Given this list of marker genes Arpc5, Lsm6, Pxdn, Plk3, Dnaja4, Pcyt1b, Vezf1, Fgfbp1, Commd6, Itm2b, Kank1, Tlcd4, Cnr1, Tmprss11e, Cdk17, Nt5c3b, Prkg1, Tsc1, Zcchc2, Sh3gl1, Gm13547, Otub2, Man1a2, Atrx, Cox6a1, Chchd6, Xaf1, Dicer1, Rapgef6, Lrrtm2, Rragc, Fbxl22, Tent5a, Nfib, Kdm2b, Sgcz, Cnot2, Cacnb2, Slc25a23 (NCBI Gene Id 66972), Calhm2, Hsd17b12, Pgpep1, Agbl5, Atp10b, Dchs1 (NCBI Gene Id 73159), Rapgef4, Icos, Oprm1, Ddb1, Magi1, Ube2v1, Ak2, Sla2, here is a description of the gene set: from publication Chen Y, Wang X (PMID 31504780) Genes predicted to be targets of miRBase v22 microRNA mmu_miR_203b_5p in miRDB v6.0 with MirTarget v4 prediction scores > 80 (high confidence targets). Mouse Gene Set: MIR_203B_5P species: Mus musculus